Given this list of marker genes Anp32a, Tmem250, Nalf1, Ubn2, Kcnj9, Tnc, Tigar, Slc25a14, Rbfox1, Calcb, Usp4, Atad2b, Ccdc96, Gcm1, Ddx19a (DEAD box helicase 19a), Maco1 (macoilin 1), Samd4, Sh3bp5l, Zfp607a, 9930012K11Rik, Pde3a, Casp3, Cyb5r3, Gpr25, Ssbp3, Rgmb, Miga2, Gm6377, Treml2, Exosc6, Pik3cg (phosphatidylinositol-4,5-bisphosphate 3-kinase catalytic subunit gamma), Tor1aip2, Igfbp5, Fundc1, Aadacl2fm1, Mob1b, Gon4l, Akap11, Mier1, Cnot4, Sod2, Sema3a, Gria3 (glutamate receptor, ionotropic, AMPA3 (alpha 3)), Cd160, Rab6b, Clock, Pde3b, Irs1, Dnmt3a, Cilk1, Cald1, Ankk1, Lyz1, Tmcc2, Ano1, Ankrd17, Dpysl2 (NCBI Gene Id 12934), Tnfsf8, Pikfyve, Fzd4, Dab2, Ndrg2 (N-myc downstream regulated gene 2), Katnb1, Pskh1, Oas1a, Agap1, Foxn4, Cimip2b (ciliary microtubule inner protein 2B), Ehmt1, Kcnb1, Ppp2r2d, Slc8a1, Ldb2, Btn2a2, Brinp1, Setd3, Orai1, Adam22, Slc17a3, Aff1, Ppil1, Wdr37 (NCBI Gene Id 73143), Cyp2u1, Sccpdh, Edn3, Zfp74, Ildr2, Scin, Fam210a, Ppfia2, Krtap16-3, Aadacl3, Trim9, Gng2, Gabrg1, Klhl24, Pdia3, Cdk19, Glis2, Arl5a, Ppfibp1, Orai3, Il21r, Pcmtd2, Scn4b, Mmp1a, Cyb561d1, Upf1, Cfap90, Rbm25, Chd8, Fam234b, Ybey, Phldb1, Tmtc2, Shoc2, here is a description of the gene set: Genes predicted to be targets of miRBase v22 microRNA mmu_miR_7032_3p in miRDB v6.0 with MirTarget v4 prediction scores > 80 (high confidence targets). from publication Chen Y, Wang X (PMID 31504780) Mouse Gene Set: MIR_7032_3P species: Mus musculus